The following is a description of a gene set: Mouse Gene Set: GOBP_NEGATIVE_REGULATION_OF_TRANSLATION_IN_RESPONSE_TO_STRESS Any process that stops, prevents or reduces the rate of translation as a result of a stimulus indicating the organism is under stress. studied in species Mus musculus, and this is the list of marker genes: Map3k20, Ang, Rbm4, Eif2ak3, Pml, Dnajc3, Sesn2